Given this list of marker genes XK, SCN3A, ATXN10, HTRA2, MT-ND1, TGFBR2, CYFIP2, VPS35, YIF1B, PDE10A, FOXG1, NDUFA13, SLC46A1, CYP27A1, GBA1, SCN2A, STXBP1, PDGFB, PLP1, MECR, PODXL, ATP1A3, PPP3CA, PIK3CD, MSH6, DHDDS, CAMK2B, CUX2, PANK2, CHMP2B, NEUROD2, MT-TV, AGA, SLC6A3, LRRK2, TRIM8, JAM2, CHEK2, ARX (aristaless related homeobox), NDUFS4, PGAP1, SIL1, MICU1, ADCY5, SQSTM1, SLC16A2, GNAO1, TSEN2, DDX3X, MT-TK, FASTKD2, SYT1, SEMA4A, PARS2, MSH2, SYNGAP1, MT-ND3, ITPR1, DNM1 (NCBI Gene Id 1759), BMPR1A, GABBR2, YWHAG, GABRA2, ATP13A2, HECW2, PLA2G6, PRRT2, BRCA2, MT-TL1, SLC13A5, SYNJ1, KCNA1, WWOX, GNAS, CHKA, NALCN, CASK, ATP6V1A, PI4K2A, GABRG2 (gamma-aminobutyric acid type A receptor subunit gamma2), STX16, SCN1B, TRAK1, SUOX, KNSTRN, VPS13A, SLC32A1, CNKSR2, PRKRA, ATXN7, PACS2, SLC39A14, PMS1, MT-ND5, POLE, MT-ND6, WIPI2, SZT2, PURA, PIGP (phosphatidylinositol glycan anchor biosynthesis class P), KCNA2, NECAP1, DNAJC6, CDKL5, NTRK2, DNAJC13, MT-ND4, COX11, UNC80, EXOSC5, CACNA2D1, SLC35A1, PNKD, COQ2, FGF14, FZR1, MUTYH, CLTC, POLD1, MDH2, NMNAT1, DALRD3, KCNC2 (potassium voltage-gated channel subfamily C member 2), DEAF1, KRAS (NCBI Gene Id 3845), TMEM43 (NCBI Gene Id 79188), SLC38A3, GRIN2D, DNAJC19, RAB39B, HCN1 (NCBI Gene Id 609), RPS20, CELF2, EPCAM, FBXO28, MT-ATP6, SCN8A, PNKP, PRKN, B4GALNT1, PMS2, CACNA1A, MT-ND2, SIK1, PARK7, MT-TW, ATM, GBA2, WARS2, KCNN2, DMXL2, SNCA (NCBI Gene Id 6622), SLC2A1, SLC30A9, VPS13C, TSEN54, MLH1, ATG7, C9orf72, GRIN2B, CACNA1B, IREB2, DDC, POLR3K, EEF1A2, ATP1A2, LRPPRC, UCHL1, NDUFS8, BCAS3, PNPT1, DPYS, FGF12, GIGYF2, GRIN1, AARS1, FTL, SLC25A22, ACTL6B, GABRA5, SLC25A10, GRM7, UBA5, PIK3CA, AP3B2, GABRB2, ACAT1, SCN1A, PINK1, MRE11, EIF4G1, GABRB3, KCNB1, PIGQ, SLC1A2, SLC18A2, NUS1, CDK19, MRM2, here is a description of the gene set: Dyskinesia species: Homo sapiens A movement disorder which consists of effects including diminished voluntary movements and the presence of involuntary movements. Human Gene Set: HP_DYSKINESIA